Given this list of marker genes IFNA5, IFNA4, IFNA10, IFNA2, DHX9, IFIH1, NPM1, IFNK, IFNA16, RIPK2, DHX36, RIOK3, NFKBIA, PQBP1, IFNA1, RALB, CAV1, IFNA21, IFIT1, SLC3A2, STING1, COLEC12, FLOT1, IFNW1, NFKB1, DDX1 (DEAD-box helicase 1), TLR3, DDX21, IFNA8, TICAM1, PDE12, RIGI, IRAK3, OAS3, MAVS (NCBI Gene Id 78993), IFNA6, ZCCHC3, MUL1, CGAS, MAPK1, CARD9, IRF3, P2RX7, KCNJ8, IFNB1, RFTN2, OAS1, IFNA14, IFNA7, IFNE, HCFC2, PMAIP1, IFNA17, MAPK3, PELI1, RFTN1, GRIA1, here is a description of the gene set: species: Homo sapiens Any process that results in a change in state or activity of a cell or an organism (in terms of movement, secretion, enzyme production, gene expression, etc.) as a result of a double-stranded RNA stimulus. Human Gene Set: GOBP_RESPONSE_TO_DSRNA